The following is a description of a gene set: species: Mus musculus Mouse Gene Set: GOMF_GALACTOSIDASE_ACTIVITY Catalysis of the hydrolysis of galactosyl compounds, substances containing a group derived from a cyclic form of galactose or a galactose derivative., and this is the list of marker genes: Glb1, Glb1l3, Gm1110, Gla, Glb1l2, Naga, Glb1l